The following is a description of a gene set: Any process that results in a change in state or activity of a cell or an organism (in terms of movement, secretion, enzyme production, gene expression, etc.) as a result of a steroid hormone stimulus. Mouse Gene Set: GOBP_RESPONSE_TO_STEROID_HORMONE studied in species Mus musculus, and this is the list of marker genes: Atp1a2, Nr0b1, Cad, Maob, Srarp (steroid receptor associated and regulated protein), Fech, Bche, Ube3a, Sox10, Safb2, Hspa8, Cry2, Ifnb1, Hnrnpu, Tbl1x, Scgb2a2, Hmgb2, Igf1, Rnf6, Hmgcs2, Rbfox2, Cd38, Pappa, Sst, Ppp5c, Sstr3, Zfp36l1, Scnn1b, Gba1, Clock, Gsk3a, Kmt2d, Ccl2, Adh1, Trerf1, Ddx17, Ncoa1, Ptges3, Zfp747l1, Ncoa3, Eif4e, Hdac8, Foxh1, Sult1a1, Lcat, Cldn1, Npas4, Uri1, Csn1s1, Tgfb3, Cry1, Srd5a2, Nr3c2, Kank2, Slit3, Ywhah, Gnrh1, Phb1, Adm, Zfp747, Isl1, Col1a1, Ncor2, Sstr5, Adam9, Dab2, Tmf1, Acr (acrosin prepropeptide), Ptpru, Nedd4, Zdhhc7, Dnaja1, Akap13 (A kinase anchor protein 13), Pcsk1, Mapk1, Esrrg, Padi2, Skp2, Alpl (NCBI Gene Id 11647), Fkbp4, Pgr, Pten, Cdkn1a, Ugt1a1, Gabrb1 (NCBI Gene Id 320243), Parp1, Tcf21, Inhba, Epo, Cnot9, Alad, Tspo, Sox30, Calcoco1, Ass1, Brca1, Pak1, Ddx5, Cps1, Ptgs2, Ace, Sirt1, Etnppl, Trip4, Ugt1a6b, Lbh, Hsd11b2, Ddit4, Rest, Tyms (thymidylate synthase), Hdac6, Stc1, Fosl2, Pdcd7, Mgarp, Cnot1, Nefl, Cybb, Abca2, Sva, Agxt, Zbtb7a, Abcc1, Lox, Ufl1, Safb, Paqr8, Pfkfb1, Lmo3, Pagr1a, Pdx1, Wbp2, Gdnf, Zfp36l2, Aqp1, Cnot3, Gkn2, Kdm5d, Hmga2, Rxrb, Gsk3b, Dsg2, Aanat, Atp1a1, Foxa1, Comt, Htr7, Adcyap1, Crh, Abcb1a, Gper1, Crebrf, Zfp366, Ncoa2, Rnf14, Ppargc1b (NCBI Gene Id 170826), Acsbg1, Ghsr, Hdac1, Pou4f2, Yap1, Aldh3a1, Pik3ca, Kdm4c, Esrrb, Src, Arid1a (NCBI Gene Id 93760), Trp63, Edn1, Il17a, Serpinf1, Cav1, Anxa1, Trim63, Ep300, Sfrp1, Tat, Esr2, Htr1b, Klf9, Calcr, Mir155, Jund, Agl, Agtr2, Rxra, Ghrhr, Scnn1g, Map2k1, Tgfb2, Ubr5, Glb1, Pck1, mt-Nd3, Bmal1, Fas, Npc1, Ptgds, Foxo3, Cst11, Akr1c18, Zfp764, Gad2, Foxp1, Oxt, A2m, Fshr, Card9, Ucn, Ncor1, Slc12a3, Errfi1, Rwdd1, Spp1, Trim68, Bmi1, Cnot2, Gpr83 (NCBI Gene Id 14608), Star, Il6, Ppp1r9b, Lats1, Il10, Tacr1, Paqr7, Prmt2, Casp9, Pcna, Atp5f1a, Axin2, Sstr2, Ptafr, Nr3c1, Nkx2-2, Trh, Mstn, Zmiz1, Abhd2, Egfr, Gstp1, Vps54, Fbxo32, Igfbp2, Txnip, Sgk1, Vps11, Per1, Rela, Pde3a, Oxtr, Stk39, Heyl, Fosl1, Sdc1, Srebf1, Rpl27, Acta1, Esr1, Tfpi, Rps6kb1 (NCBI Gene Id 72508), Slco1b2, Calr, Ube2l3, Areg, Ucn3, Jak2, Adipoq, Casp3, Nr1h3, Mettl21c, Cyp7b1, Carm1, Cyp1b1, Ufsp2, Ddrgk1, Acod1 (aconitate decarboxylase 1), Aifm1, Smarca4, Pck2, Scgb1a1, Zfp36, Cpn1, Ufm1, Tnf, Nkx3-1, Sstr4, Rhoa, Bckdhb, Ntrk2, Park7, Ucp2, Myod1, Avpr1a, Fam107a, Gpi1, Hmgb1, Ptger2 (prostaglandin E receptor 2 (subtype EP2)), Uba5, Daxx, Phb2, Bmp4, Nodal, Ugt1a6a, Med1, Smyd3, Got1, Pias2, Por, Esrra, Hnmt, Tbx2, Ctsl, Mbp, Ucp3, Junb, Gh, Jun, Acaa1a, Th, Agtr1a, Taf7, Pik3r1, Fos, Agtr1b (NCBI Gene Id 11608), Fosb, Or51e2, Usp26, Fkrp, Scnn1a, Anxa3, Il1rn, Rxrg, Shq1, Kdm3a, Idh1, Bmp6, Asns, Mdm2, Abca3, Bdnf, Rbbp7, Pf4, Dnaaf4, Cldn4, Bcl2, Eif4ebp1, Ppara, Zfp764l1, Vps18, Strn3, Foxo1, Adra1b (NCBI Gene Id 11548), Ar, Cxcl2, Cdo1, Gjb2, Tgfb1, Mir21a